Given this list of marker genes Sdc3, Hpse, Gusb, Sdc1, Hpse2, Naglu, Sdc2, Gpc2 (NCBI Gene Id 71951), Glb1l3, Glb1l2, Sgsh, Gpc6, Ids, Sdc4, Idua (iduronidase, alpha-L), Hgsnat, Agrn, Gpc1, Gpc5, Gpc3 (NCBI Gene Id 14734), Gpc4, Glb1l, Glb1, here is a description of the gene set: studied in species Mus musculus Mouse Gene Set: REACTOME_HS_GAG_DEGRADATION HS-GAG degradation